The following is a description of a gene set: Mouse Gene Set: GOMF_MELANOCORTIN_RECEPTOR_ACTIVITY Combining with melanocortin to initiate a change in cell activity. species: Mus musculus, and this is the list of marker genes: Oprm1, Mc5r, Mc2r, Mc4r, Mc3r, Mc1r